Given this list of marker genes Rps28, Rpl19, Eif3i, Rps4x, Rpl26, Eif3b, Eif3d, Rpl37rt, Rpl7, Rps13, Rps12, Rps6, Rps23, Rpl3l, Rps15, Rpl18, Rps8, Rps17, Eif4a1, Rps3a1, Rps2, Rpl37a, Eif5b, Rps7, Rpl27a, Rpl18a, Rpl11, Rps27l, Rps25, Pabpc1, Rpl13, Rps20, Rpl36al, Fau, Rpl39l, Rpl6, Eif3g, Rps19, Rpl27, Rps10, Rps9, Rps24, Eif3k, Rpl39 (ribosomal protein L39), Rpl37 (ribosomal protein L37), Rpl15, Rplp2, Rps26, Rps5, Rpl23a, Rpl38, Eif3e, Eif2b4, Rpl9, Ubb, Eif1ax, Eif4a2, Rpl24, Rpl4, Rps18, Eif3j2 (NCBI Gene Id 100042807), Rpl14, Eif4ebp1, Rpl29, Eif2s3x, Rpl36a, Rpl12, Rpl3, Eif3f, Rps11, here is a description of the gene set: species: Mus musculus part of: Eukaryotic Translation Initiation Reactome Pathway: Cap-dependent Translation Initiation electronically inferred by orthology from the curated human pathway This event has been computationally inferred from an event that has been demonstrated in another species.<p>The inference is based on the homology mapping from PANTHER. Briefly, reactions for which all involved PhysicalEntities (in input, output and catalyst) have a mapped orthologue/paralogue (for complexes at least 75% of components must have a mapping) are inferred to the other species.